Given this list of marker genes CANT1, KIF22, COG1, COL11A2, EXTL3, DYM, COMP, COL2A1, PLOD3, LONP1, RNU4ATAC, IFT140, CHST3, HS2ST1, PIK3C2A, TRAPPC2 (trafficking protein particle complex subunit 2), TRPV4, SMARCAL1, CDC6, MATN3, ADAMTSL2, GLB1, here is a description of the gene set: Absent epiphyses studied in species Homo sapiens Human Gene Set: HP_ABSENT_EPIPHYSES